Given this list of marker genes NFE2L2, AGR2, SGTA (small glutamine rich tetratricopeptide repeat co-chaperone alpha), PIK3R1, TMEM259, BCAP31, ERN1, HERPUD1, NCK1, RNF185, RNFT2, BAK1, STUB1, BOK, UBQLN1, TMEM33, WFS1, ATXN3, BAX, RNF183, PMAIP1, TMX1, DDIT3, PTPN1, ATXN3L, UBQLN2, NCK2, BBC3, DAB2IP, CAV1, RNFT1, BAG6, ATF6, APP, PTPN2, USP13, FCGR2B, XBP1, SERINC3, SIRT1, BCL2L11, here is a description of the gene set: Any process that activates or increases the frequency, rate or extent of response to endoplasmic reticulum stress. species: Homo sapiens Human Gene Set: GOBP_POSITIVE_REGULATION_OF_RESPONSE_TO_ENDOPLASMIC_RETICULUM_STRESS